Given this list of marker genes MUC1, FOXC2, DPH2, CEP83, HLA-DRB1, SLC12A3, SLC30A9, WDR19, INVS, FAN1, TRAF3IP1, DPH1, BTNL2, PUS3, UMOD, BCS1L, FOXP3, CLCNKB (NCBI Gene Id 1188), IFT122, MRPL3, CPT2, SLC7A7, ALMS1, MMUT, here is a description of the gene set: species: Homo sapiens A form of inflammation of the kidney affecting the interstitium of the kidneys surrounding the tubules. Tubulointerstitial nephritis Human Gene Set: HP_TUBULOINTERSTITIAL_NEPHRITIS